Given this list of marker genes CERS1 (NCBI Gene Id 10715), SPTLC2, SGMS2, CYB5B, CSNK1G2, ABCC1, SGMS1, OSBP, KDSR, PPM1L, ORMDL3, PRKD1, SPHK2, PRKD2, SPTSSA, FA2H, DEGS1, CERS5, VAPB, CERS3 (NCBI Gene Id 204219), SPTLC3, SPNS2, ABCG2, CERS6, ORMDL1, SPHK1 (sphingosine kinase 1), CERS2, DEGS2, SPTLC1, CERS4, VAPA, SPTSSB, PRKD3 (NCBI Gene Id 23683), CERT1, MFSD2B, SAMD8, ORMDL2, here is a description of the gene set: Reactome Pathway: Sphingolipid de novo biosynthesis part of: Sphingolipid metabolism species: Homo sapiens Glycosphingolipid biosynthesis is based on salvage of sphingolipids and de novo sphingolipid synthesis. Sphingoid-1-phosphate signalling molecules are synthesized through the same pathway, which starts with the transfer of a fatty acid onto serine. The diversity of products results from later dehydrogenation or hydroxylation of fatty acid moieties, as well as the usage of fatty acids of different lengths. Biosynthesis takes place in the endoplasmic reticulum lumen and the cytosol. Lipophilic products are transported to other membranes via a specialized transporter (CERT1) or the secretory pathway. Soluble sphingoid-1-phosphates are exported by multiple transporters in the plasma membrane.